The following is a description of a gene set: species: Homo sapiens A reproductive process occurring in the mother that allows an embryo or fetus to develop within it. Human Gene Set: GOBP_MATERNAL_PROCESS_INVOLVED_IN_FEMALE_PREGNANCY, and this is the list of marker genes: GHRL, CSMD1, DAZAP1, NR2F2, PRDM1, STOX2, AKT1, AR, ENSG00000274276, ACE2, DSG2, DCAF13, PRDX3, ASH1L, TMED2, APOL2, VDR, HMX3 (H6 family homeobox 3), PTGIS, JUNB, LGALS9, KPNA6, PPARD, CTSB, CYP27B1, PGR, EPOR, DEDD, GHSR, PARP2, CBS, WNT4, ITGA3, TCF23, SPP1, ANGPT2, NODAL, HAVCR2, ADCY7, STC2, ESR1, LIF, TPPP3, KLF1, PTN (NCBI Gene Id 5764), DSG1, RXRB, IHH, NDP, STC1, PARP1, MED1, RGS2, BMPR2, BSG, NPFF, PTGS2, AGRP, LDOC1, CITED2